The following is a description of a gene set: Human Gene Set: DANG_MYC_TARGETS_DN Genes down-regulated by MYC and whose promoters are bound by MYC, according to MYC Target Gene Database. species: Homo sapiens from publication Zeller KI, Jegga AG, Aronow BJ, O'Donnell KA, Dang CV (PMID 14519204) We report a database of genes responsive to the Myc oncogenic transcription factor. The database Myc Target Gene prioritizes candidate target genes according to experimental evidence and clusters responsive genes into functional groups. We coupled the prioritization of target genes with phylogenetic sequence comparisons to predict c-Myc target binding sites, which are in turn validated by chromatin immunoprecipitation assays. This database is essential for the understanding of the genetic regulatory networks underlying the genesis of cancers., and this is the list of marker genes: CSDE1, ID3, LAMP1, NDRG1, PDGFB, DNTT, TMEM126A, GTF2H2, ILK, DLEU2, LAMC1, MYC, HMOX1, ALDH9A1, ERBB2, ITGB1, MSN, TGFB1, ACP5, PTPN1, SERPINE1 (NCBI Gene Id 5054), ARPC4, ZFP36L1, SFXN3, CDKN2B, RARA, PTPA, CDKN1B, APP, CEBPA, VHL